Given this list of marker genes EXOC3, RAB27A, CPE, KIF5A, PCSK1, EXOC6 (NCBI Gene Id 54536), EXOC2, KIF5B, MYRIP, MYO5A, EXOC5, EXOC7, STX1A, P4HB, KIF5C, ERO1B, CLTRN, EXOC4, EXOC1, EXOC8, SLC30A5, VAMP2, SLC30A8, PCSK2, INS, here is a description of the gene set: Human Gene Set: REACTOME_INSULIN_PROCESSING Insulin processing studied in species Homo sapiens